The following is a description of a gene set: Mouse Gene Set: GOBP_NEGATIVE_REGULATION_OF_MACROPHAGE_DERIVED_FOAM_CELL_DIFFERENTIATION species: Mus musculus Any process that decreases the rate, frequency or extent of macrophage derived foam cell differentiation. Macrophage derived foam cell differentiation is the process in which a macrophage acquires the specialized features of a foam cell. A foam cell is a type of cell containing lipids in small vacuoles and typically seen in atherosclerotic lesions, as well as other conditions., and this is the list of marker genes: Abca5, Ppara, Hbp1, Itgb3, Crp, Pparg, Nfkbia, Itgav, Adipoq, Abcg1